The following is a description of a gene set: Human Gene Set: GSE3982_EOSINOPHIL_VS_NKCELL_DN from publication Jeffrey KL, Brummer T, Rolph MS, Liu SM, Callejas NA, Grumont RJ, Gillieron C, Mackay F, Grey S, Camps M, Rommel C, Gerondakis SD, Mackay CR (PMID 16474395) Genes down-regulated in comparison of eosinophils versus NK cells. In the present study we used Affymetrix oligonucleotide microarrays to produce gene transcription profiles for the major leukocyte types in humans. This comprehensive dataset enabled us to not only establish which genes were expressed in each leukocyte type, but also which genes were expressed in each subset after activation. The used of a comprehensive dataset of gene profiles from all the major human leukocyte subsets enabled a novel and powerful means for identification of genes associated with single leukocyte subsets, or different immune paradigms. species: Homo sapiens, and this is the list of marker genes: AKR1C3, EIF4B, TRIT1, UNC5C, SLC12A7 (NCBI Gene Id 26129), DNAJC15, CD99, NNMT, AMZ2, RNF220, EPS8L3, IL27RA, CAMLG, LRRC8D, SMC2, IFT46, TXN2, MFAP5, RUVBL1, MLST8, ATP8A2, MRPL16, METRN, LAIR2 (leukocyte associated immunoglobulin like receptor 2), SUCLG2, PARN, PROSER1, EIF3E, C2CD2, KLRA1P, FBL, KCNH4, PDE6G, ANKRD17, LTBP3, ANO2, MDH1, PSME1, RPF1, PEPD, MGST3, RPL4, MAPKAPK5-AS1, PRKX, IARS2 (isoleucyl-tRNA synthetase 2, mitochondrial), GADD45GIP1, SEMA4C, COG2, FBXO40, CSNK2A2 (casein kinase 2 alpha 2), SEPTIN6, COLGALT2, FHIP2B, IL19, DFFA, PEX11A, MINPP1, CTSH, TARP, RAD17, ABCD4, KCNQ3, TRIM14, RUSC1, CCDC25, FOXD1, CCDC144A, OLA1, LDB2, MCM3 (minichromosome maintenance complex component 3), DLGAP5, NDUFA9, SEPTIN8, PLAC8, VPS51, CAST, CACNA2D3, YIPF1, NCAM1, ANO10, ARRB1, PVRIG, WDR37, HOXB8, BABAM2, BLMH, MRPL34, HSD17B3, PEMT, PKD1P1, LCK, COQ3, ADGRG1, DNAJC16, ZKSCAN8, ABCF2, TPMT, PSG7, MAP3K14, KLRB1, LIPF, PTK2B, FBXO21, UPK3A, MLLT11, SEMA5A (NCBI Gene Id 9037), PLCH2 (phospholipase C eta 2), FKBP11, HCP5, LRRC41, DPAGT1, PRR3, ZNF32, MANF, JAK1 (Janus kinase 1), TMEM45A, CYFIP1, MRTFB, MTSS1, IL10RA, AKR1A1, FAM168A, MSX1, PAICS (phosphoribosylaminoimidazole carboxylase and phosphoribosylaminoimidazolesuccinocarboxamide synthase), HCG9, SIGIRR, APOOL, SMC1A, CCT7, CABYR, CISD1, KIFAP3, IFI16, MRPL3, SNRPD3, TERF1, CEP72, IFT140, ITGA10, NSA2, RNF139 (NCBI Gene Id 11236), STAT4, LRRC37BP1, PALLD, DNAJA3, KSR1, UBE4B, H3C11, NELFA, ATP5F1C, DPYD (NCBI Gene Id 1806), ATP5IF1, PEX5, SMARCC1, GCLM, NOS1AP, NPY1R, CD1B, PIP4K2B, DYRK4, HMG20A, RERE (NCBI Gene Id 9642), RANGAP1, OPRPN, FRK, KLRC4, RACGAP1, WDR7 (NCBI Gene Id 23335), ZNF473, PSMD6, RMDN3, RPL7A, RPS16, CBR3, MTX1, ABLIM1, LMAN2L, CYP2B7P, TSPAN3, ILRUN, HSPE1, PCBP3, PIK3C2B, ENDOD1, OSBPL3, ANXA2P1, PHYH, AOAH, TTK, HSD3B2, CD247, RPP40, BLCAP, SPOCK2, XYLT2, JADE2, FH, F2RL3